Given this list of marker genes RGS4, MAPK14, DUSP14, MBD2, ABLIM1, AXL, ADCY9, ACTA1, ARPC4, CAP2, ATP2A2, TUBB2A, SH3BP4, MAPRE2, STAT1, THBS1 (thrombospondin 1), ATP9A, AKAP12, GEM, PMAIP1, DAPK1 (NCBI Gene Id 1612, death associated protein kinase 1), KRT18, BECN1, ARL6IP5, TYRO3, ITGA3, PDLIM3, FLNC, HSD17B1, PTPN1, PTPRE, CARD10, PLCL1, TLN1 (talin 1), TP53, CDKN1C, VCL (vinculin), CYFIP2, KIDINS220, PPP2R5C, RAB33B, MAPK6, ACP5, ARHGAP1, RANGAP1, ACTA2, DYRK3, TRIB1, RASAL2, TUBA1A, TPM2, STK24, CFLAR, DAB2, SMARCA4, PPP3R1, PI4K2A, ARL4C, DHRS3, ADCY7, PAWR, ACTN1, NPC2 (NPC intracellular cholesterol transporter 2), STK17A, CTNND1, TNFRSF11B, MAP4K4, CDK14, RPRM, MAP2K3, SMARCD1, TP53I11, ILK, EZR, CHUK, RAB5C, PRKD1, ACTG2, TLK1, CASP4, GBP1, CAPZA1, PIK3CD, RGS5, REXO5, ITGB5, here is a description of the gene set: Genes down-regulated in primary granulosa cells after stimulation with LH or FSH gonadotrophic hormones for 24 h. from publication Sasson R, Rimon E, Dantes A, Cohen T, Shinder V, Land-Bracha A, Amsterdam A (PMID 15026540) Human Gene Set: SASSON_RESPONSE_TO_GONADOTROPHINS_DN species: Homo sapiens Gonadotrophins exert a major effect on ovarian development and on the control of fertilization. By stimulating cells with forskolin (FK), it is possible to study which genes are activated by gonadotrophins via the cAMP cascade, and which by alternative pathways. Using RNA isolated from stimulated cells, we found that 59% of the total genes modulated by LH were also modulated by FK, while 69% of the genes modulated exclusively by FSH were also modulated by FK. Gene transcripts involved in steroidogenesis/progesterone production were highly elevated, while 17beta-hydroxysteroid dehydrogenase was down-regulated. This suggests that a decrease in the conversion of androstenedione to testosterone and estrone to estradiol occurs during luteinization. Down-regulation of genes coding for actin cytoskeleton proteins and cytokeratin 18 was observed in response to gonadotrophin and cAMP stimulation. Several of the genes coding for the microtubule network were also modulated, implying that rearrangement of the cytoskeletal proteins permits better coupling between organelles involved in steroidogenesis. A dramatic change in gene transcripts coding for signalling enzymes was observed following LH stimulation. This includes the down-regulation of adenylyl cyclase 7 and 9, elevation of cAMP-dependent phosphodiesterase, and the up-regulation of a negative regulator of G-protein signalling (RGS16) that may negate gonadotrophin signalling via guanine nucleotide binding proteins. Thus luteinized cells, despite increased gene transcripts to LH/chorionic gonadotrophin (CG) receptors, respond inefficiently to gonadotrophin stimulation, due to attenuation of signal transduction in the cAMP cascade at multiple steps. Novel genes involved in the regulation of apoptosis were found for the first time to be up-regulated by gonadotrophin stimulation, including: BAX inhibitor-1, granulysin and apoptosis repressor with caspase recruitment domain (ARC). These proteins may be involved in a unique alternative pathway of ovarian cell death. Such a pathway could temporarily preserve the mitochondria and progesterone production during the initial stages of granulosa cell apoptosis.